The following is a description of a gene set: Genes containing one or more binding sites for (PHB2) in their promoter regions (TSS -1000,+100 bp) as identified by GTRD version 20.06 ChIP-seq harmonization. studied in species Homo sapiens from publication Yevshin I, Sharipov R, Kolmykov S, Kondrakhin Y, Kolpakov F (PMID 30445619) Human Gene Set: PHB2_TARGET_GENES, and this is the list of marker genes: RUSF1, RNVU1-32, CHPT1 (choline phosphotransferase 1), ZFPM2, DDA1, NXT2, FOXO3 (forkhead box O3), EXOSC10, SFRP5, LINC02772, FKBP8, TBKBP1, RNU5F-1, BLTP3B-DT (BLTP3B divergent transcript), RABEP2, NACC1, PIK3AP1 (phosphoinositide-3-kinase adaptor protein 1), PRKD1, ENSG00000260592, ASIC4, SEPTIN9, HDDC2, RNVU1-26, RNFT2, CPXM1, LINC00431 (NCBI Gene Id 104355135), ARFGEF2, RNY3P11, EHD1, RHBDD1, WIPI2, RPL22L1, AAAS, HMBS, USP20, AXL, DAAM1, LYL1, IL1R1, LAMP1, YPEL4, ENAM, GYPE, ABT1P1, DNAJB2, TESMIN, SLC22A7, WWC2-AS1, MIR4252, CPQ, KRTAP1-3, BLTP3B, ACRBP, TMCC3, PIGL, TNS1, VILL, TMEM116, YJU2, PDE6G, CHMP3, TMBIM1, ZNF83, HOMER2 (homer scaffold protein 2), MIR4766, CA1, SIN3B, RNVU1-19, SIGLEC27P, HEMGN, CEP95 (NCBI Gene Id 90799), MIIP, MARCHF2, FAM234B, CHD4, RNU6-169P, MCAM, MEGF11, NFIX, AHI1, DDX1, TBL3, SYN3, UROD, CRPPA-AS1, PPP1R15A, NUP155, MFAP3L, NFE2, PLA2G6, RNF43, MAN2A2, NFKBIE, SSBL4P, S100Z, UBTF, CLTC, RFX1 (regulatory factor X1), DNHD1, MIR1205, BCCIP, TRAPPC9, CAMK2N1, TKFC, IQGAP1, CHCHD2, ERCC2, AFG2B, ATP2B4, ENSG00000232884, PISD, GFI1B, FOXO4, DAZAP1, C17orf58, KCNQ4, RPS21P8 (ribosomal protein S21 pseudogene 8), GUK1, NME2, AQP8, UBE2O, ARRDC2, TBC1D4 (TBC1 domain family member 4), PTMS, ACSL6, RHOBTB3, TATDN3, NECTIN2, ZCCHC24, RPS16, GYPB (NCBI Gene Id 2994), MYO5B (myosin VB), CCDC162P, RANBP1, HDAC6, ENSG00000266976, EXOSC7, MIR4729, SMG1, TCP10L2 (t-complex 10 like 2 (pseudogene)), ATG4D (NCBI Gene Id 84971), RN7SKP192, CFAP418-AS1, FAM83A-AS2, LINC02928, AGRN, SLC8A2, KIRREL2, MIR4441, ASIC1, BSG, CRKL, SRD5A3-AS1, MIR130AHG, UBE2QL1, FCMR, EGFL7, PLEKHA4, CLP1, WNK4 (WNK lysine deficient protein kinase 4), RNA5SP324, MEF2C-AS1, GYPA, PREX1, ARF4, UQCC3, UCA1, GARRE1, TILAM, POGLUT1, MIR4659B, UBASH3A, DNAAF5, RBPJL, CLEC16A, BAHCC1, GET4, NPL, ENSG00000253986, PRSS8, PPOX, NIPSNAP2 (NCBI Gene Id 2631), CCDC137P1, SDE2, RUNX1T1, SPTAN1, RNVU1-14, KLHL22, CASS4, NECAB2, TCP11L2, SNORD3J, C11orf21, NLRP7, FAM83A, G6PD, SPMIP8, RIPOR3, SPINK4, GMFB, CNGB1, TFR2, TRMT1, ENSG00000227706, KLRK1-AS1, UROS, FAXDC2